Given this list of marker genes Angptl8, Ccn3, Wnt3a, Nr1d1, Rasgrf1, Map2k1, Ggcx, Phox2b, Bglap, Igfbp3, Tcf19, Igf1, Birc5, Igfbp4, Dach1, Raf1, Wdr13, Fmc1, Reg1, Adk, Sgpp2, Nkx6-1, Serpinb1a, Ptprv, Bad, Nr4a3, Bglap2, Irs2, Sidt2, Pdx1 (NCBI Gene Id 18609), Igfbp5, Cdk4, Ptprn, Phip, Errfi1, Sfrp1, Serpinb1c, Nupr1, Nr4a1, Serpinb1b, Men1, here is a description of the gene set: The multiplication or reproduction of pancreatic B cells, resulting in the expansion of an pancreatic B cell population. Pancreatic B cell are cells of the pancreas that secrete insulin. studied in species Mus musculus Mouse Gene Set: GOBP_TYPE_B_PANCREATIC_CELL_PROLIFERATION